The following is a description of a gene set: Genes predicted to be targets of miRBase v22 microRNA hsa-miR-5590-3p in miRDB v6.0 with MirTarget v4 prediction scores > 80 (high confidence targets). from publication Chen Y, Wang X (PMID 31504780) Human Gene Set: MIR5590_3P studied in species Homo sapiens, and this is the list of marker genes: EPAS1, CZIB, ARID4B, STARD13, MAP4K3, STK38L, ASB7, ZNF587, ATP1B4, CREBRF, NBEA, AFF4, STX17, GAB1, FGF12, CISD2, SNX1, AQP11, ADIPOR2, DIO2, BMPR1A, C8orf34, ANGPTL5, RB1CC1, BRD1, PRELID2, MYCN, ACTN4, PRP4K, ZFPM2, PDS5B, GK5, NFE2L2, NT5C1B-RDH14, LPP, ZSCAN12, TMX3, TRPC4, AADAC, ABHD13, ACSL6, DBR1, ZNF680, SLC7A11, MTR, WWP1, ITGAV, RERG (RAS like estrogen regulated growth inhibitor), ZFPL1, PLEKHA3, HOXD8, ATXN7L2, UBE2D1, RGPD4, ADGRL3, NKX3-1, CDK19, DENND1B, CCNT2, ARID2, PTP4A1, ACKR3, PSAT1, ZNF503, FAM199X, LACTB, SPAG9, RAD50, CYTH2, PIK3C2A, BICD1, CDK17, CCSER1, NEDD4L, KRAS, FBXL3, RAP1A, REST, MCM10, CD109, B3GNT5, HIPK1, TRIM13, MAN1A1, LSM8, PRKG1, CADM2, MOSPD2, SLC24A2, ZBTB11, MARCHF6, CCDC80, SRSF6, DYNC1I2, NUP133, DYNLT1, APPL1, BRWD3, ZCCHC14, ABCA1, GBP5, SOX7, POGLUT3, PPP3R1, SUPT7L, PAIP1, SMAD5 (NCBI Gene Id 4090), YOD1, DIAPH2, GNG12, MBNL3, HDLBP, LDB2, SACS, KBTBD12, IGF1, TRIM36, ST8SIA1, MID2, STK17B, CNEP1R1, ZMYND11, PRDM8, ANGPT2, CUL4A, APPBP2, ARSJ, ZDHHC2, FBXO30, CA8, SLC15A5, CLIC4, VPS50, RNH1, CAV2, SGCE, MAP3K2, CEP290, MED6, ACER3, PTPN4, TRUB1, USP9X, SLC25A21, TENM3, TBL1XR1, ZNF454, EXO1, HOOK3, SLC18A2, SSH1, MAL2 (mal, T cell differentiation protein 2), RSF1, GUCY1A2, ATP13A3, RNF138, MAGI2, GDNF, NFAT5 (nuclear factor of activated T cells 5), ANGEL2, VGLL3, HSD11B1, OTUD4, ZNF624, LMX1A, RHOA, BOD1L1, CIT, SLAIN1, LRP1B (LDL receptor related protein 1B), SH3KBP1, SIX4, ADAM20, STC1, MLH3, KGD4, NENF, UBE2A, RC3H1, DAP3, CBLN4, PDCD6IP, FIGN, ANKRD28, ANKIB1, IL17F, ZNF445, PPP6C, CYLD, MYO1D (NCBI Gene Id 4642), VMP1, CNTN1, EIF5A2, CD69, KNG1, CPNE4, NEXMIF, ZBTB20, RGPD5, CFAP65, KLF10, GCC2, ABHD10, CILK1, MED28, HAPLN1, HELQ, TTL, DMD, KITLG, CHSY3, FGD6, ZNF131, PGM2, ATP1B1, HYCC1, RAB11FIP5, MTFR1, HSPH1, ZNF471, MAL, TRIM2, LEPROT, MARVELD3, BCOR, TVP23B, EFCAB14, GAS7, PIK3CA, IL22, DLGAP1, TCF21, SELENOT, HNRNPH3, FAM131B, METTL6, SNX3, LRP12, ALS2, BVES, FEM1C, PROM1, ROBO1, BTBD1, OGFRL1, ERH, ANKS1B, ACADSB, CCNG2, DNAJC7, MED12L, ZC3H12B, NCK2, ADAMTS1, TRIM23, CXADR, ELAVL4, SDHB, ZC3H12C, BAZ2A, SWSAP1, GPR155, FAM91A1, TVP23C, DNAI7, NFX1, MAP3K20 (mitogen-activated protein kinase kinase kinase 20), BNIP2, IFIT5, RORA, CD5L, GPC6, PLAUR, CLK4, STAG1, S1PR1, SLC9A6, ETV1, SYNJ1, ZXDC, ZNF736, SOCS1, RAB6B, C11orf71, SLC12A2, CSMD3, MED14, DLG1, TMEM265, VPS54, KLF8, CCL28, MFSD9, TAFA1 (NCBI Gene Id 494552), RGPD8, TNS1, RHOQ, FHIT, CEP57L1, MTMR10, ZBTB37, ONECUT2, NCKAP1, SAMD12 (sterile alpha motif domain containing 12), RPS6KA5, DNAJB4, AHR, KCNA4, FCHO2, GOPC, STXBP4, ACTC1, ABCB5, ARHGEF6, ZNF770, DNAJC25, MED17, UFL1, SLC30A4, IGF2BP3, RRP15, MKLN1, PRPF40A, ADGRB3 (adhesion G protein-coupled receptor B3), ACBD5, BHLHE41, SH2D1A, RWDD4, NR2C1 (nuclear receptor subfamily 2 group C member 1), NPAT, ZNF239, STAU1, MCMDC2, FGFR1OP2, IGFL1 (NCBI Gene Id 374918), NBN, PHYHIPL, TOPORS, CAPN7, MTCP1, TBC1D9, ZNF326, CAPN10, CLVS2, SMAD2, SGMS1 (NCBI Gene Id 93538), NR1I2, RGPD6, ADAMTS5, UBE4A, BMI1, COMMD3-BMI1, NALF1, UBE3B, LHFPL3